Given this list of marker genes Khsrp, Pcsk9, Apoc3, Mylip, Abcc8, Ldlr, Il19, Csk, here is a description of the gene set: species: Mus musculus Any process that decreases the rate, frequency or extent of low-density lipoprotein particle clearance. Low-density lipoprotein particle clearance is the process in which a low-density lipoprotein particle is removed from the blood via receptor-mediated endocytosis and its constituent parts degraded. Mouse Gene Set: GOBP_NEGATIVE_REGULATION_OF_LOW_DENSITY_LIPOPROTEIN_PARTICLE_CLEARANCE